The following is a description of a gene set: Mouse Gene Set: GOBP_POSITIVE_REGULATION_OF_PROTEIN_KINASE_A_SIGNALING Any process that increases the rate, frequency, or extent of protein kinase A signaling. PKA signaling is the series of reactions, mediated by the intracellular serine/threonine kinase protein kinase A, which occurs as a result of a single trigger reaction or compound. studied in species Mus musculus, and this is the list of marker genes: Iapp, Adissp, Nrxn1, Adrb2, Tcim, Mif, App, Akap12, Adipoq, Ramp3, Calcr (NCBI Gene Id 209117)